The following is a description of a gene set: from publication Ben-Porath I, Thomson MW, Carey VJ, Ge R, Bell GW, Regev A, Weinberg RA (PMID 18443585) Set 'Eed targets': genes identified by ChIP on chip as targets of the Polycomb protein EED in human embryonic stem cells. species: Homo sapiens Human Gene Set: BENPORATH_EED_TARGETS Cancer cells possess traits reminiscent of those ascribed to normal stem cells. It is unclear, however, whether these phenotypic similarities reflect the activity of common molecular pathways. Here, we analyze the enrichment patterns of gene sets associated with embryonic stem (ES) cell identity in the expression profiles of various human tumor types. We find that histologically poorly differentiated tumors show preferential overexpression of genes normally enriched in ES cells, combined with preferential repression of Polycomb-regulated genes. Moreover, activation targets of Nanog, Oct4, Sox2 and c-Myc are more frequently overexpressed in poorly differentiated tumors than in well-differentiated tumors. In breast cancers, this ES-like signature is associated with high-grade estrogen receptor (ER)-negative tumors, often of the basal-like subtype, and with poor clinical outcome. The ES signature is also present in poorly differentiated glioblastomas and bladder carcinomas. We identify a subset of ES cell-associated transcription regulators that are highly expressed in poorly differentiated tumors. Our results reveal a previously unknown link between genes associated with ES cell identity and the histopathological traits of tumors and support the possibility that these genes contribute to stem cell-like phenotypes shown by many tumors., and this is the list of marker genes: NEUROG1, GPR88 (NCBI Gene Id 54112), SGPP2, ARHGAP20, SOX5, COL25A1, TUBA4A, VASH1, MED31, HSPA1A (heat shock protein family A (Hsp70) member 1A), FOXF2, PLPPR1, CTCF, DARS2, USH1G, ADGRG6, TGFA, PRKG1, SIM2 (SIM bHLH transcription factor 2), PRELID1, HEY1, OXCT2, MAB21L2, DLK1, ANKRD19P, TAC1 (tachykinin precursor 1), SOX21, IL1RAPL2, WNT16, HES7, PRICKLE1 (NCBI Gene Id 144165), RGS6, HOXC6, SLC30A3, HAND2, TMEM65, WNT7A, NPAS1, FBXO39, ZIC1, HSPA1B, RNF128, ANKRD20A8P, ADRB1, DSCAML1, TPPP3, EVX1, H4C12, CDKN2C, MIR137HG, H3C11, ISL1, RAB6C, PLA2G7, ACP7, DLGAP5, ST8SIA5, CAMK2N1, H4C13, CLCN5, ATAD3B, OR8A1, FGF10 (fibroblast growth factor 10), PARD3, SLC6A10P, DOCK11, CFAP91, HOXA10, EPB41L4B, TNFRSF11A, ZMYND15, FBLN7, ONECUT2, ROBO3, TBX22, ASCL2, SORCS1, CDT1, SPON1, OLFML2B (NCBI Gene Id 25903), H2BC12, CSMD1, SLFN11, GPR50, FGF20, SLITRK4, CBLN1, H3C8, FOXC1, GSTA4, GNA14, MOXD1, FRMPD4, GRIN3A, CIDEA, OTX2, H4C2, GATA3, ABCC8, PITX1, CTSD (cathepsin D), CCDC170, MT1A, RIPK3, ADRB3, KLF4 (KLF transcription factor 4), ADCY4, HSPA6, KCNK2 (potassium two pore domain channel subfamily K member 2), FERD3L, KLHL35, NPPC, CGB8, UBE2K, PCDH17, GUCY1A1, NT5C1A, H2AC12, DMRTC1, SLC35D3, MNX1, FARSA, FLRT2, FBN2, H2AC15, PLXND1, AHR (aryl hydrocarbon receptor), PMP22, SLC6A5, TBX1, TNFRSF25, TRPA1, GABRB2, CACNA1G, GPM6B, TRHDE-AS1, ESX1, ANKRD20A1, IRX2-DT, H2AC11, DCHS2, NRCAM, MAP7D2, PIP5K1B, C1orf122, FLI1, TIGD5, TSLP, OTUD6B, TMEM26, GADD45G, CH25H, MT1X, EPB41L4A-DT, NKX6-2, H2AC16, WNT3A, EOMES, UCP1 (uncoupling protein 1), FBXL14, DIO3, GPC5, LAYN, ASTN1, OLIG2, TMOD2, OTOP3, QRFPR, MYO5B, PAX3, HOPX, MT1P3, DMRT2 (doublesex and mab-3 related transcription factor 2), CDX2, LGR5, ANOS1, SLC30A2, GAD1, EPAS1, PODN, IER5L (immediate early response 5 like), HHEX, HOXC4, CXorf58, STEAP4, DLX4, RNF152, NFIX, PIGZ, SLC10A4, RASGRP1, HOXB7, PARP12, ZNF436, NKX2-2, ADAMTS15, GHR, SLC8A3, DUOXA2, KCNK12, TFAP2B, PCDH10, LRCH2, MCHR2, INHBB, TBX2, TCF21, CACNA1B, EGR4, PHOX2A, RYR3, BACH2, POU4F1, MSX1, DCLK1, SHROOM1, C2CD4A, RUNX2, ZMAT5, ALX1, GAD2, COL9A2, TCEAL8, NEFL, FIGLA, COL24A1, BRINP3, H4C8, FOXD4L3, CUEDC1, UCN, HOXA1 (NCBI Gene Id 3198), NKX3-2, VSX2, SCRN1, ZCCHC14 (zinc finger CCHC-type containing 14), TTPA, TMEM132E, LRP2, NPY1R, FOXG1, LPL, HSPA1L (heat shock protein family A (Hsp70) member 1 like), PGR, H4C3 (NCBI Gene Id 8364), H2BC13, SOX17, FRMD3, MICB, ERBB4, FOXD3, KCNQ3, GPR6, GABRA2, SLCO4A1, WLS, ANKRD13C-DT, RGS9BP, PTGR3, PLXNC1, ADGRL3, SYT12, ATP1B3, EVA1C, HTR2C, GFI1, NKX6-1, DRD5, SIX1, SLC30A4, PTGER2, H4C16, CAMK2B, TBCB, NTRK1, ZFYVE28, GDF6, RPRML, H4C9, F2R, GIMAP5, ST8SIA2, HOXD3, ERICH5, NKX3-1, SIDT1 (SID1 transmembrane family member 1), MPHOSPH6, RIMBP3C, RGCC, CLEC14A, FEZ1, HOXD11, TFAP2D, RBM24, GPAT3, RIMBP3B, SSTR1, SIX5, ZNF436-AS1, MORF4L2, PTGER3, NKX2-8, FGF3, CALCA, RASL10A (NCBI Gene Id 10633), IL7, SCN4B (sodium voltage-gated channel beta subunit 4), HS6ST3, PKNOX2, GABRA4, TRH, FZD10, PAPPA, TMEM88, NKPD1 (NCBI Gene Id 284353), DACH1, FGF5, RAB32, GATA6, PTF1A, POLR2I, CRLF1, HOXC12, DNAJC22, SLIT2, ULBP2, HTR1A, RIMKLA, LRATD1, SIX3, GPR101 (G protein-coupled receptor 101), MMD2, TRIM7, WNT6, EML5, CMTM2, ABCA8, AQP5, PPM1E, STK17A, BARHL2, CD44, FOXD4L4, CTNND2, KL, HPCAL4, FEZF2, TGFB2, DGKG, NDUFA13, CBLN4, B4GALNT2, CGB7, MOB2, FFAR4, PDGFRA, DUSP4 (NCBI Gene Id 1846), AUTS2, TRHDE, ELOVL2, H3C7, SDC2, PGM5, PAX7, POU3F2, SLC35F3, BRINP2, HNF1B, CNTFR, HLF, EN1, HLA-C, FNDC1, ANKRD20A3P, GATA3-AS1, HBA1, BNC1, IGF2-AS, ENSG00000255537, SFRP4, HMX3, DCLK2 (doublecortin like kinase 2), LTK, SOX3, GATA2, LMX1B, CHST8, DHRS13, TCF15, ULBP1, ANXA2R-AS1, HTR7, CCDC140, EPHX3, FUZ, DPY19L2P2, HTR1E, TMEM106C, NTN1, PDE8A, FZD1, TRIM9, EBF1, PHF3, TBR1, PCDH8, SIX2, SLC24A4, RELN, ONECUT1, PARM1, ARL9, THBD, PNRC2, SHOX2, HTR1B, HOXC9 (homeobox C9), ZNF365 (zinc finger protein 365), SLIT1, RTN4RL2 (reticulon 4 receptor like 2), HTRA1, EPHB1, BCL2L10, NAGS, RASGRF1, H3C4, PITX3, ELAVL2, SLCO2A1, KCNV1 (potassium voltage-gated channel modifier subfamily V member 1), TRIM67, GRM7, NTRK2, PENK, EGFR, PAX9, FAM89A, BTG2, TWIST1, HOXB8, RBP4, ITGA4, OSR1, GALR2, NEUROD2, COL4A6, TLL1, IRAK3, TRPC5, PRAC1, CD8A, SNAP91, SORCS2, NRIP3, ADAMTS5, SCNN1G, SCTR, ALKAL1, CRHBP, DPF3, FAM43B, PDZD2, IGF2, H1-0 (H1.0 linker histone), WT1-AS, H4C6 (H4 clustered histone 6), EMX2, NTN4, VGLL2, WT1, SFRP1, HOXD13, ZBTB7A, TBX20, GRID1, LBX1, GBX2, DCC, FUCA2 (NCBI Gene Id 83934), LHX5, TM6SF1 (NCBI Gene Id 53346), BHLHE22, MT1H, FOXL1, NEUROG3, ADARB2, ESPN, STK32B, H4C14, CRYBG1, GRM3, CYP26C1, RIN3, HLA-G, HBA2, H3C6, VDR, COL19A1, EPHA5, VSTM4, HMX2, COCH, BMP6, FEV, OLIG1, RPS6KA6, SETD7, MYOD1, RFX6, BARX1, LOX, CRYBA2, GINS1, KCNC4, ANKRD13C, OTOP2, TFAP2E, EGR3, NR2E1, ADM, PRKCE, ADAMTS18, NEUROD1, NOG, TBX3, SLC9A2, TAP1, CYP27B1, SHISA2, MDGA1 (NCBI Gene Id 57164), BMAL1, CBR3, FAM163A, FOXD2, LRRC71, VWA3B (von Willebrand factor A domain containing 3B), APBB1IP, C17orf100, MAF, CCN2, KIRREL3, DDAH1, B4GALNT1, SLC32A1, STC2, STMN2, SYT10, STXBP6, H4C1, HOXB2, LHX4, SRD5A2, FOXF1, ESYT3, PLXNA2, FZD2, BMPR1B, MSX2, FOXD4L1, DLX3, HOXC8, PDE4DIP, PCSK1N, IGSF21, CLSTN2, CITED1, TLX2, OGFRL1, SLC1A4, KCNA3, HOXD1, CXCL12, INA, JMJD1C, PPP1R10, PITX2, IRX3, NR4A3, B4GALT6, MAB21L1, HLA-A, HOXB13, SHOX, GCM2, TBL3, TBX21, DKK1, IL20RA, H4C11, SCIN, TAFA4, RASSF5, GLIPR2, ADAP2, KCNMA1, VSIG2 (NCBI Gene Id 95982), NPTX1, GDF7, CD34, H2AC13 (NCBI Gene Id 8329), OPRD1, IGFBP7, SOX7, HHAT, RAI2, HS6ST1P1, CLTRN, CORO6 (coronin 6), GATA4, TMEM59L, NEFM, GDNF, HYOU1, AFF2, NPTX2, GSX2, IGFBP3, HOXD9, HOXC13, FAM168B, PCID2, POU3F4, MRPS18B, KCNK13, PRDM12, UPF3A, KCND3, PABPC1L2A, TSSK6 (testis specific serine kinase 6), CYP24A1, GRIA2, TLX1, ESAM, POU3F1 (POU class 3 homeobox 1), OTOP1, ALOX5, SLC18A3, TAL1, KCNAB1, MYF6, DRD4, COLGALT2, WRAP73, CFAP276, SLC9A3, RAB24, ZNF711 (zinc finger protein 711), CALCR, DGKI (diacylglycerol kinase iota), GJB2, ANKRD27, H3C10, TBXT, RSPO2, MEGF11, YRDC, HAP1, HOXA4, LHX2, TET2, ADRA2A, SCUBE3, CDH23, KCNH1, DACH2, CHODL, ZNF335, NRN1, GALNT10, MAPT, PXMP2, LRFN2, CACNA1D, HOXD8, DLX2, FOS, HRK (harakiri, BCL2 interacting protein), NELL1, SLC25A33, DHH, EFNA1, TMEFF2, EPS8, PTH2, ITPKA, GALNT18, KCNQ5, HHIP, PPP1R14C, MID1, BAIAP2, PLCB1, PRDM14, DSP, HOXB1, C11orf87, FOXE1, FUT4, AMOT, LMO1, FBP1, KY, ANXA2R, HIC1, ACYP2, CHRD, CYP26B1, DUOXA1, CDK5R2, LCORL, SF3A2, VGF, BMP8A, ACVR1C, NEUROG2, SIM1, TMEM132E-DT, CXCL14, FGF9, DPY19L2, CLIC5, PTPRU, MCOLN3, SHH, KCNH3, CXCL16, BARHL1, DENND3, SLC6A3, TSPAN6, CACNA1E, PAX6, MSC, DKK2, CNNM2, OTX1, SLC26A4, OTP, TMEM30B, KCNK17, FOXB1, HS3ST3B1, ABHD15 (abhydrolase domain containing 15), WNT11, CLIP4, DLX1, NKX2-3, GPR12, P2RX5, GSC2, SEMA6D, SOX1, ASTN2, ARID3C, PKP1 (plakophilin 1), PLEC, GSDME (gasdermin E), ABTB2, NKAIN2, PHOX2B, CFTR, RSL1D1, GDA, MT1B, HOXA7, SLITRK1, REPS2, EPHB3, SLC1A2, HOXA9, GREB1L, EEF1D, FOXJ1, TUBA4B, SOX14, SRRM2, ATOH1, MESP1, MTSS1, GRIK3, DLX5, PIR, IRX5, FZD8, CNNM1, ZBTB16, CCBE1, COLEC12, JUN, HPSE2, MAP3K5, LHX8, DSC3, WASL, PROK2, MGARP, LHFPL3, COMP, MLNR, PTAR1, ASAH1, H2BC17, DLL4, GSX1, ATF3, SLC6A1, TRADD, SLCO5A1, ANKRD18A, APOO, ZIC4, BHLHE41, NRG1, MLLT3, CA10, DMRT1, BMP3, CHRDL2, CUL4A, HNRNPM, MT1DP, NDUFA4L2, HES2, CASZ1, H3C12, HSF4, POU4F2, CFAP299, CREG2, BCL2, IRX4, DOK6, ECEL1, FBXO3, SLITRK3, PTGER4, TRIM36, SHC4, BAIAP2-DT, MT1M, PAX8, PYY, NTNG2 (NCBI Gene Id 84628), PAPOLA, SERTM1, ST8SIA1 (ST8 alpha-N-acetyl-neuraminide alpha-2,8-sialyltransferase 1), MED11, LRRC47, MAP3K3, LINC02875, YAF2, EGFL6, ZNF503, LHX6, LYSMD2, GJD2, PAX1, PDE10A, COL2A1, DMRT3, ZFHX3, EEF2, LAMP5, OAF, NKX2-5, EN2, VAX2, HLA-B, CYP1B1, ZEB2, TP73 (tumor protein p73), HOXB6, KLK4, TBX5, VSX1, HLX, SUSD4, MAPK4, METRNL, HOXD4, GUCY2D, WNT2, GSC, VAX1, PTGFR, ASCL1, GRIK1, ISL2, RAX, GFRA1, ZIC2, CYP26A1, LGALS3, SHISA6, LYPD1, BTG4, MYB, ALOX15, CRACDL, NGB (NCBI Gene Id 731373), KCNA1, CHN2, EDEM2, NPR3, KCNJ6, BATF3, NOL4, HAND1, KAZALD1, H3C2, BMI1, VIPR2, EYA2 (EYA transcriptional coactivator and phosphatase 2), ADRA1A, AATF, KCNQ1, HOXC5, PDX1, CNRIP1, UNC5C, INSM2, CD70, ZNF517, LRFN5, H4C4, GRK5, TLX3, FAM81A, SOD3, INSRR, SIX6, H4C5, H2AC18, SPOCK3, HOXB3, RGS20, KCNC2, NEURL1, HOXA2, NCAM1, NPAS4, C7orf57, TCEA3, SLC22A3, IKZF3 (IKAROS family zinc finger 3), U2AF2, CDC7, ANKRD20A5P, COL4A5, PTGDR, SORCS3, PTHLH, FOXL2, TTYH1, SELENOS, ALX4 (NCBI Gene Id 64068), CEMIP, INTU, CRTAC1, EFNA3, SHQ1, FOXA2, CEBPD, RSPO1, UQCR10, UAP1L1, EPB41L4A, WNT10A, CA3, H2AX, ANKRD20A2P, H3C3, NINL, ADCY8, TRMO, CENPL, NR2F2, PAX2, PSD2, WNT10B, KCNJ2, MEOX2, CBX8, PRLHR, SSTR2, HOXD12, BVES, BARX2 (BARX homeobox 2), EYA4, ICAM5, H2AC17, LRRTM1, FOXQ1, INPP4A, WNT1, DUOX2, ALX3, ETV7, NXPH4, CSMD3, ELAPOR1, HCG9, SLC27A2, SV2B (NCBI Gene Id 9899), RIMBP3, COL12A1, HOXA3, NBPF11, MKX, RTL4, HOXA13, LONRF3, ANKRD18B, OCA2, SCD5, KCNK4, ILDR2, RGS10, ZCCHC2, PRDM13, PRKCB, CDH7, ADCYAP1, NPNT, ASXL1, PTPRT, SPAG6 (sperm associated antigen 6), SATB2-AS1, MT1JP, ELMOD1, GHSR, RSPO3, FBXL8, PLEKHJ1, MAL (mal, T cell differentiation protein), URI1, CRHR1 (corticotropin releasing hormone receptor 1), BHLHE23, LTBP2, MAFB, SFRP5, INTS4P1, MAGI2, CSNK1E, ATOH8, NKX2-1, POLE, COL27A1, ARID1A, POU4F3, HOXC11, NAV2, OLIG3 (oligodendrocyte transcription factor 3), HOXA6, H3C1, ELAVL1, ANKRD9, DUOX1, NRG2